Given this list of marker genes HADH, MRPL33, ELOVL1, UGDH, CDK1, PPP2CB (NCBI Gene Id 5516), SERPINB2, PDE6C, EBP, HGSNAT, SLAIN2, RPF2, NIP7, FOXP1, MARCHF6 (NCBI Gene Id 10299), NDUFB11 (NADH:ubiquinone oxidoreductase subunit B11), MAT2A, SLC25A33, MRRF (mitochondrial ribosome recycling factor), ERO1B, IL18RAP, NPRL3, BDH1, MMP8, SLC37A4 (solute carrier family 37 member 4), FBXO33, MPO, MAST1, SEC62, COQ3, IVNS1ABP, RNF26, TMEM41A, SASH3, POLR3K, CDADC1, OPN3, ZNF148, ORMDL1, EIF3I, RRAS, RPL14, NCAPH2 (NCBI Gene Id 96652), CD320, PLAUR, PPT2, HDHD2, ST3GAL5, STARD4 (StAR related lipid transfer domain containing 4), RENBP, SEC61B, ZBTB1, ATP5MF, SIGLEC7, CHADL, ABCC1, CETN3, NDUFC2, YPEL3, TOB2, LAPTM5 (NCBI Gene Id 7805), SMC4, BMP6, MRPS11, NUDT5, CKS1B, UBALD1, ENTPD4, POF1B, IL1B, PNO1 (NCBI Gene Id 80711), DBI, TINAGL1, SNX21 (sorting nexin family member 21), MBTD1, EMC7, TRAPPC1, PRKD3, BCAS2, KRT72, PGRMC2, GAD1, COX8A, PRSS35, SDHC, CEP68, ARHGEF1, MYO7A, MTIF2, PPP1CC, DPAGT1, TAF9, KLHL7, NFYC, GDAP2, RNF187, PGLS, BANF1, MRPS28, TMEM37, PRKCB, MFF, RAB7A (RAB7A, member RAS oncogene family), RNF167, CEP57L1, SNX12, CD200R1, SLC35A1, GLRX3, FAM3C, PBDC1, BIRC5, ACOX1, EEF1AKMT1, EFNA1, SPO11, ECHS1, CHEK2, NDUFA6 (NADH:ubiquinone oxidoreductase subunit A6), IMP3, SQOR, FKBP4, GSTM1, OAT, SDC1, MCM7, TALDO1 (NCBI Gene Id 6888), NEDD8, PEA15, PPP2R1A, ZFP82, CLCC1, MYL1, MLLT10, GLCE, WASHC2A, CSGALNACT2, DHRS11, KLF7, FAHD1 (fumarylacetoacetate hydrolase domain containing 1), ATL2, ZDHHC6, TM2D2, SCN7A, CDC25A, E2F6, PRKAG2, HSD17B7, STAMBPL1, ISYNA1, PLPBP, F3, C1QTNF12, TRIM3 (tripartite motif containing 3), CCT3, STX1A, MRPL3, ACSS2, NUCKS1 (nuclear casein kinase and cyclin dependent kinase substrate 1), P2RY6, FAM50A, CNIH1 (NCBI Gene Id 10175), RMND5B, S1PR1, PLA2G2E, KCTD12, RBFOX2, S100A6, RPL5, STARD7, SDHA, RPL12, RPL27A, RBM12, ACTR6, CYB5A, MECR, ARHGEF12, CSTB, SWI5, DIPK2A, ECD, METAP2, STAG2, VIPR1, SEPTIN8, IFITM10, NOMO1, LMAN2, NEK9, MLH1, CISD1, CLEC5A, ZC3H14 (NCBI Gene Id 79882), MRPS16, CIB2 (NCBI Gene Id 404086), GPX1, TOMM6, SDHAF4, here is a description of the gene set: Human Gene Set: GSE17721_LPS_VS_PAM3CSK4_12H_BMDC_DN from publication Amit I, Garber M, Chevrier N, Leite AP, Donner Y, Eisenhaure T, Guttman M, Grenier JK, Li W, Zuk O, Schubert LA, Birditt B, Shay T, Goren A, Zhang X, Smith Z, Deering R, McDonald RC, Cabili M, Bernstein BE, Rinn JL, Meissner A, Root DE, Hacohen N, Regev A (PMID 19729616) mouse primary BMDCs were stimulated with tlr ligands and gene expression changes were profiled on Affymetrix arrays Genes down-regulated in comparison of dendritic cells (DC) stimulated with LPS (TLR4 agonist) at 12 h versus DC cells stimulated with Pam3Csk4 (TLR1/2 agonist) at 12 h. species: Homo sapiens